Given this list of marker genes Nek7, Cct4, Cct3, Cct8, Cct7, Mapkapk5, Mapk1, Pnkp, Mapk15, Aurkb, Ptges3, Prkcq, Gch1, Cct6a, Map2k7, Rtel1, Pot1a, Acd, Nek2, Pkib, Hnrnpa2b1, Xrcc5 (X-ray repair complementing defective repair in Chinese hamster cells 5), Tcp1, Map3k4, Hnrnpd, Terc, Dkc1, Ctnnb1, Mapk3, Dhx36, Atr, Hmbox1, Fbxo4, Atm, Naf1, Wrap53, Wnt3a, Cct2, Cct5, Parn (NCBI Gene Id 74108), Tnks, Pot1b, here is a description of the gene set: Any process that activates or increases the frequency, rate or extent of telomere maintenance via telomere lengthening. Mouse Gene Set: GOBP_POSITIVE_REGULATION_OF_TELOMERE_MAINTENANCE_VIA_TELOMERE_LENGTHENING studied in species Mus musculus